Given this list of marker genes Kdm1a, Ins2, Smtnl1, Adm, Bmpr2, Vasp, Wnk1, Gdi1, Myo3a, Fgb, Wnk3, Vil1, Nck1, Kcnj8, Map1b, Sptbn1, Csf3, Lep, Tmsb4x, Gper1, Pclo, Arhgap40, Cdc42ep3, Egfr, Zfyve27, Anxa7, Hp1bp3, Slc6a12, Ccl11, Kank2, Ssh2, Mir205, Cdk4 (cyclin dependent kinase 4), Rhoa, Cln8, Atp2b1, Atp2b2, Tlr2, Dstn, Gprc5b, Gnb3, Rb1cc1, Adcy10, Nts, Comp, Adcy6, Pex11a, Nppb, Mapt, Pycard, Mt3, Cdc42ep2, Capn1, Rictor, Spta1, Npy1r, Sct, Dscam, Itgb1bp1, Pecam1, Kel, Eif2b2, Edn2, Ccl21a, Ush1c, Sctr (secretin receptor), Tnf, Wdtc1, Pls1, Pla2g6, Agt, Rock2, Baiap2l1, Fgf13, Calca (calcitonin/calcitonin-related polypeptide, alpha), Lats1, Rnf6 (ring finger protein (C3H2C3 type) 6), Bag4, F2rl1, Cdc42ep5, Manf, Borcs8, Tsc2, Htr1a, Slit2, Capza3, Dnajc16, Dbh, Vpreb1b, Plekhh2, Shtn1, Bdnf, Slc12a3, Sema3f (NCBI Gene Id 20350), Scnn1b, Tmsb15l, Vav2, Ins1, Nckap1l, Svil, Fn1, Wnt7b, Hsp90aa1, Actn2, Avp, P2rx7, Ntrk3, Lamtor4, Cacna1g, Ucn, Hdac6, Kcna5, Map3k7, Capg, Myadm, Cyfip2, Cdkl3, Adora1, Cacna1c, Alox5, Borcs5, Sod2, Shc1, Adra1b, Srf, Itgb1, Htr1d, Kdr, Fer, Mtnr1b, Cyria, Eif4g2, Rbfox2, Atp13a2, Ptk2b, Smurf1, Trim46 (NCBI Gene Id 99605), Rufy3, Gclc, Inf2, Mkks, Ace, Rab22a, Slc12a5, Borcs6, Rac1, Arhgap32, Pdxp, Smpd3, Ahr, Cdh1, Cdc42ep4, Htr1b, Cftr, Avil, Ext2, Slc12a9, Ano6, Nkx6-1, Hrh2, Ilk, Dusp5, Add1, Tacr1, Htr2b, Cntn2, Rdx, Capza2, Bcl11a (BCL11 transcription factor A), Adra2c, Rab5a, Arpc5, Rock1 (NCBI Gene Id 68785), Rnd2, Cdkl5, Npr3, Oxtr, Nefl, Ezr, Gla, Cdk5, Snapin, Slc8a1 (NCBI Gene Id 319418), Ret, Itga9, Plxna3, Nppa, Ssh1, Arpc2, Scin, Htr2c, Kat2b, Ep300, Sh3bp1, Snx9, Adrb1, Dmtn, Nos1, Omg, Adora2b, Bloc1s2, Dip2b, Cfl1, Uts2b, Tpm1, Map2k1, Itga1, Slc12a6, Map3k13 (mitogen-activated protein kinase kinase kinase 13), Casr, Hnf1b, Ptger3 (NCBI Gene Id 19218), Kank4, Cx3cl1 (NCBI Gene Id 58173), Arpc3, Pax2, Cyp2j5, Als2 (NCBI Gene Id 77293), Capzb, Cav1, Clasp2, Rab21, Rtn4, Pfn5 (profilin 5), Shank3, Ntn1, Slc26a5, Slc12a8, Lamtor5, Tenm1, Uts2, Islr2, Mgll, Ngf, Pik3ca, Lrp1, Actr3, Elavl1, Kcnn4 (potassium intermediate/small conductance calcium-activated channel, subfamily N, member 4), Arhgap35, Abcc1, Ist1, Pex11b, Tbxa2r, Draxin, Cln3, Rptor, Irag1, Picalm, Atp1a2, Arpc5l, Brk1, Rapgef3, Avpr2, Tmod3, Slc12a4, Pfn3, Dlg1, Ece1, Carmil1, Stk39, Daam2, Rtn4r, Eps8, Macf1, Dnm2, Akt3, Gba2, Sema3g, Itga4, Myo5b, Avpr1a, Lpar3, Akt1 (NCBI Gene Id 268604), Mrgprd, Wdr36 (NCBI Gene Id 70569), Dcx, Washc5, Cit, Cps1, Cdc42ep1, Pde5a, Sod1, Ccl26, Gsn, Wnt3a, Ttl, Prex1, Wnt9b, Uts2r, Bdkrb2, Abcc9, Cdh4, Plxna4, Pum2, Snta1, Clcn3, Shroom2, Ccl21d, Kxd1, Ptgs1, Dbnl, Twf2, Wnt3, Adora2a, Ifrd1, Avpr1b, Acta2, Aqp1, Twf1, Icam1, Rasa1, Ttc3, Lmod2, Ptprs, Edn3, Limk1, Was, Iqgap3, Cyfip1, Mas1, Sema3a, Vav1, Nck2, Lrrc8a, Chmp3, Myh9, Sptb, Ccl24, Pfn1, C1qtnf9, Agtr1b, Fchsd1, Bin1, Sin3a, Plekhg2, Smad6, Pak3, Baiap2l2, Map2, Trpc5, Tnfrsf12a, Gm14137, Pfn2, Esam, Pik3r2, Eln, Abitram, Sirt1, Hax1, Htr7, Bbs4, Slc12a2, Mlst8, Map3k1, Grb2, Arhgap28, Foxc1, Ptgs2, Ulk2, Trpm4, Tmod4, Vstm4, Hif1a, Fchsd2, Atg5, Wdr35, Wnt7a, F2r, Klk1b1, Npr1, Washc1, Gch1, Sod3, Cxcl12, Stub1, Cdhr5, Gucy1a1, Trp73, Naa80, Edn1, Adrb3, Ndel1, Prkce, Kng1, Lars1 (leucyl-tRNA synthetase 1), Sema7a, Prkg1, Nherf1, Tmsb15b2, Ap2m1, Gpx1, Arhgap42, Nppc, Svep1 (NCBI Gene Id 80647), Creb1, Adra2b, Il7r, Ssh3, Cfl2, Epha7, Atp7a, Trpv2, Swap70, Per2, Gja1, Scpep1, Vav3, Cd38, Arhgap4, Nefm, Cyrib, Ext1, Fga, Hrh1, Plek, Ppard, Htr2a, Baiap2 (NCBI Gene Id 97767), Gja5 (NCBI Gene Id 70659), Clns1a, Esr2, Xk, Prr16, Ccr5, Cracd, Carmil2, Tmod1, Barhl2, Msn, Arf6, Agtr2, Pdgfb, Dnm1, Sema4f, Asxl1 (ASXL transcriptional regulator 1), Mtor, Aqp4, Sema4d, Mtpn, Wdr1, Prkd1, Ednra, Grk2, Plod3, Crp, P2rx1, E2f4, Borcs7, Adra1d, Slc6a4, Lmod1, Ptk2, Dbn1, Grip2, P2ry1, Ppp1r15a, Apln, Pafah1b1, Adnp, D130043K22Rik, Rab3b, Efna5, Mfn2, Fshr, Kank1, Plekha7, Dock4 (dedicator of cytokinesis 4), Fstl4, Cav3, Lrrk2 (leucine-rich repeat kinase 2), Nrp1, Cysltr1, Ccl21e, Ogt, Alox15, Megf8, Asic2, Anapc2, Adra1a, Prkg2, Tsc1, Faah, Hmgcr, Adcyap1, Rgs2, Myo1c, Specc1l, Hsp90ab1, Kank3, Myo3b, Drd1, Mag, Flii, G6pdx, Adra2a, Abcb8, Agtr1a, Wnt5a, Akt1s1, P2rx4, Arfgef1, Serpinf2, Sptan1, Dock5, Arhgap5, Disc1, Spart, Ccdc51 (NCBI Gene Id 66658), Pten, Slit1, Rgma, Aqp11, Bloc1s6, Golga4, Tbxas1, Cbs, Adrb2, Hcls1, Kirrel1, Pou4f2, Bloc1s1, Add2 (NCBI Gene Id 72970), Gclm, Rin3, Prkcd, Pak1, Ccl21f, Tnr, Capza1b, Oxsr1, Vpreb1a, Vill, Crabp2, Sema5a, Aqp2, Klf2, Ccl21b, Foxc2, Rap1gds1, Col6a1, Ptprm, Vegfa, Lima1, Nckap1, Apoe, Ppp1r9a, Bbs2, Fxn, Fhod3, Coro1a, Nphs1, Gsk3b, Pex11g, Tmod2, Lmod3 (NCBI Gene Id 320502), Hip1r, Ednrb, P2ry2, Kng2, Cttn, Fmn1 (formin 1), Chga, Npm1, Zdhhc21, Deptor (DEP domain containing MTOR-interacting protein), Slc12a1, Drd5, Tgfbr3, Kcnmb1, Kcnma1, Olfm1, Add3, Abl1, Kdm6a, Sema6c, Chrm3, Cdhr2, Evl, Ryk, Nos3, Slc12a7, Lrrc8e, Clec2i, Ulk1, Cotl1, Rpl4, Mmp2, Fgg, L1cam, Capza1, Arhgap18, Sema6d, Neb, here is a description of the gene set: Mouse Gene Set: GOBP_REGULATION_OF_ANATOMICAL_STRUCTURE_SIZE studied in species Mus musculus Any process that modulates the size of an anatomical structure.